Given this list of marker genes NES, PKIA, NANOS1, RBMS1, WARS1, DEPTOR, CST3, PLP2, PDIA6, TAGLN2, CD86, CKS1B (NCBI Gene Id 88475), PRSS16, IL27RA, NTAN1, CCDC167, DOCK11, TP53BP2, S100A4, DPM3, OPN3, RAPH1, EIF4EBP2, IRF2BP2 (NCBI Gene Id 359948), GAREM1, TMEM107 (NCBI Gene Id 84314), TSEN15 (NCBI Gene Id 92120), MYO1B, CD52, APBB1IP, LHPP, TMBIM6, MSTO1, TIMP1, DNAJC12, TPGS2, TCFL5, AGA, ITGB8-AS1, SGPL1, GBA1, TBCE (NCBI Gene Id 6905), ST3GAL1, KCNN3, AP1S2, DEK, CALHM2, here is a description of the gene set: Top 50 down-regulated genes in cluster HP of multiple myeloma samples characterized by a hyperploid signature. species: Homo sapiens To better define the molecular basis of multiple myeloma (MM), we performed unsupervised hierarchic clustering of mRNA expression profiles in CD138-enriched plasma cells from 414 newly diagnosed patients who went on to receive high-dose therapy and tandem stem cell transplants. Seven disease subtypes were validated that were strongly influenced by known genetic lesions, such as c-MAF- and MAFB-, CCND1- and CCND3-, and MMSET-activating translocations and hyperdiploidy. Indicative of the deregulation of common pathways by gene orthologs, common gene signatures were observed in cases with c-MAF and MAFB activation and CCND1 and CCND3 activation, the latter consisting of 2 subgroups, one characterized by expression of the early B-cell markers CD20 and PAX5. A low incidence of focal bone disease distinguished one and increased expression of proliferation-associated genes of another novel subgroup. Comprising varying fractions of each of the other 6 subgroups, the proliferation subgroup dominated at relapse, suggesting that this signature is linked to disease progression. Proliferation and MMSET-spike groups were characterized by significant overexpression of genes mapping to chromosome 1q, and both exhibited a poor prognosis relative to the other groups. A subset of cases with a predominating myeloid gene expression signature, excluded from the profiling analyses, had more favorable baseline characteristics and superior prognosis to those lacking this signature. Human Gene Set: ZHAN_MULTIPLE_MYELOMA_HP_DN from publication Zhan F, Huang Y, Colla S, Stewart JP, Hanamura I, Gupta S, Epstein J, Yaccoby S, Sawyer J, Burington B, Anaissie E, Hollmig K, Pineda-Roman M, Tricot G, van Rhee F, Walker R, Zangari M, Crowley J, Barlogie B, Shaughnessy JD Jr (PMID 16728703)